Given this list of marker genes F8, here is a description of the gene set: Retention of A2 polypeptide is required for normal stability of activated factor VIII (FVIIIa) and dissociation of A2 correlates with FVIIIa inactivation and consequent loss of FXase activity. Hemophilia A (HA)-associated mutations (R550H, A303E, S308L, N713I, R717W and R717L) within the predicted A1-A2 and A2-A3 interface are thought to disrupt potential intersubunit hydrogen bonds and have the molecular phenotype of increased rate of inactivation of FVIIIa due to increased rate of A2 subunit dissociation (Pipe SW et al. 1999; Hakeos WH et al. 2002) part of: Defective factor VIII causes hemophilia A Reactome Pathway: Defective F8 accelerates dissociation of the A2 domain species: Homo sapiens